Given this list of marker genes Mttp, Pltp, Abca3, Scp2, Pitpnb, Pitpna, here is a description of the gene set: species: Mus musculus Mouse Gene Set: GOMF_PHOSPHATIDYLCHOLINE_TRANSFER_ACTIVITY Removes phosphatidylcholine from a membrane or a monolayer lipid particle, transports it through the aqueous phase while protected in a hydrophobic pocket, and brings it to an acceptor membrane or lipid particle.